Given this list of marker genes TTN, ABCC9, COQ4, POMT2, POLG, TNNT2, GATAD1, LMOD2 (NCBI Gene Id 442721), PLN, PSEN1, POLG2 (NCBI Gene Id 11232), SGCG, AARS2, DMD, ENPP1, TOP3A, TWNK, B2M, MRPL39, GNPTAB, MYL3, BAG5, MYOZ2, CORIN, SDHA, PSEN2, ACTN2, TAFAZZIN, TXNRD2, GET3, ABCC6, ACTC1, RRM2B, ANKRD1, TCAP, KLHL24, COA6, TNNC1, BAG3, GTPBP3 (NCBI Gene Id 84705), FHOD3, FKTN, MYH7, TNNI3, SLC25A4, NEXN, PPP1R13L, RAF1, VEZF1, PRDM16, KCNJ5 (potassium inwardly rectifying channel subfamily J member 5), DES, DSG2, ACADVL, CSRP3, RRAGD, TPM1, RBM20, LAMP2, TAF1A, FLII, MYPN, LAMA2, KCNJ2 (potassium inwardly rectifying channel subfamily J member 2), DOLK, JPH2, VCL, MYBPC3, PPCS, LMNA, TMPO, SCN5A, FHL2, RPL3L, TTR, SDHD, GJA5, HAND2, RRAGC, NPPA, LAMA4, LDB3, DYSF, ZMPSTE24, CRYAB, MYZAP, MYH6, SGCD, DSP (desmoplakin), SLC6A6, CAP2, here is a description of the gene set: Left ventricular systolic dysfunction studied in species Homo sapiens Abnormality of left ventricular contraction, often defined operationally as an ejection fraction of less than 40 percent. Human Gene Set: HP_LEFT_VENTRICULAR_SYSTOLIC_DYSFUNCTION